The following is a description of a gene set: Genes predicted to be targets of miRBase v22 microRNA hsa-miR-188-3p in miRDB v6.0 with MirTarget v4 prediction scores > 80 (high confidence targets). Human Gene Set: MIR188_3P from publication Chen Y, Wang X (PMID 31504780) species: Homo sapiens, and this is the list of marker genes: SBDS, PCLO, SNX11, IGF2BP1, PDIK1L, RMND5A, ZNF705EP, ZNF705D, SLK, RAD21, STAG2, UBE2D3, RGS7BP, METTL15, NCAPG2, FANCL, ZNF37A, GPATCH2L, NXPH2, MSL1, KCNMB3, UBQLN4, IKZF2, ZNF700, CCL11, HSPA14, TRIM4, ATXN1, TOR1AIP2, KLRG1, ZNF80, TSPAN2, SIAH2, BRAP, BRK1, ZNF773, APLF, TARDBP, CPNE5, ZNF384, GPX4, USP27X, APBA1, RUFY3 (NCBI Gene Id 441022), NEUROG2, ARPP21, RAB26, NRXN2, FREM2, ARID5B, IPPK (NCBI Gene Id 79194), ADCY1, ZNF544, SLC7A11, DLX1, TTC17, ARRDC3, NEXMIF, ZHX2, ZNF135, KRBOX4, NR6A1, WWC3, ZNF584, ATP8B1 (ATPase phospholipid transporting 8B1), DGKH, SLC22A13, ZNF106, ZNF195, ZFYVE16, MAPK13, ZNF189, ZNF594, INSYN2A, SURF4, SORCS3, TRIM5, ARL4A, BCL9, CDK1, ZNF221, ZNF302, IL12RB1, ZNF781, ZNF208, ZNF780B, SENP2, DDHD1, STAU2, ZNF268, ZNF175, ZNF180, SUMF2, DNAJC14, THEMIS2, FZD5, KLHL29, SMAP2, ZNF814, NRN1, MAPK10, MED1, TUSC2, ZNF177, NALF1, ZFX, ZNF705A, CHRDL1, ZNF439, ZNF562, PRMT3, ZNF14, ZNF844, ABL2, ZNF763, RNF145, ZNF440, ZNF181, ZSCAN16, ALDH5A1, ZNF565, ZNF563, CEP57L1, ARL8B (NCBI Gene Id 55207), ZNF124, SET, LGI1, ZNF559, ZNF780A, NIPBL, OXGR1, ZNF514, CHEK1, TACR2, SMPDL3A, ZFP90, ZNF75A, SPMIP5, ZNF732, ZNF586, ZNF367, EOGT, WBP11, GRID2, GCC1, ZNF426, LCLAT1, RNF150, IGDCC3, DIDO1, TET1, ZNF559-ZNF177, CSNK2A1